The following is a description of a gene set: Mouse Gene Set: GOCC_NUCLEAR_INCLUSION_BODY An intranuclear focus at which aggregated proteins have been sequestered. studied in species Mus musculus, and this is the list of marker genes: Rad18, Slf1, Atxn1, Tpr, Nup98, Pabpn1, Ranbp2, Nxf1, Stub1, Atxn3, Ifi204, Nup153, Nbn (nibrin)